Given this list of marker genes MCM8, TBPL1, NCOA2, ZC3H7A, IRF6, RER1, MDGA2, TMEM209, SAMD9L, SLC25A31 (NCBI Gene Id 83447), MAP2K4, GLUD1, SLC10A1, RPE, LRRC18, CAV2, HDAC9, KCNB1, DCK, ZNF567, SLC31A2, RGMB, ROM1, FRMD5, PIAS2, AGAP1, FZD4, SH3KBP1, SLC24A2, PAX8, LYSMD1, CLIC6, RNF24, ZNF230, GRIK1, RAP2A, SLF1, NCBP1, CSTF2, LINC02873, SDC2, DOCK7, WDR33, CERT1, ARHGAP12, RIOX2, PMAIP1, EBAG9, SLC9A2, SRRM4, ZSWIM6 (NCBI Gene Id 57688), DEUP1, NIPSNAP3B, ENSG00000286190, HYKK, ETV1, GOLGA7, BTG2, here is a description of the gene set: from publication Chen Y, Wang X (PMID 31504780) Human Gene Set: MIR8081 Genes predicted to be targets of miRBase v22 microRNA hsa-miR-8081 in miRDB v6.0 with MirTarget v4 prediction scores > 80 (high confidence targets). studied in species Homo sapiens